Given this list of marker genes Sncb, Muc2, Cox17, Atox1, Sncg, Prnp, Snca, Park7, Atp7a, here is a description of the gene set: Binding to a cuprous ion, copper(1+). Mouse Gene Set: GOMF_CUPROUS_ION_BINDING species: Mus musculus